The following is a description of a gene set: Cytochrome P450 4F22 (CYP4F22) is thought to 20-hydroxylate trioxilin A3 (TrXA3), an intermediary metabolite from the 12(R)-lipoxygenase pathway. This pathway is implicated in proliferative skin diseases. The major products of arachidonic acid in keratinocytes are 12- and 15-HETE which undergo biotransformation to products involved in skin hydration. CYP4F22 mutations can lead to autosomal recessive congenital ichthyosis 5 (ARCI5). species: Homo sapiens part of: Metabolic disorders of biological oxidation enzymes Reactome Pathway: Defective CYP4F22 causes ARCI5, and this is the list of marker genes: CYP4F22